Given this list of marker genes Slc23a1, Zfp983, Cntnap2, 6330403K07Rik, Pkhd1l1, Grap2, Isg15, Prnp, Pak6, Sfrp1, C1qtnf4, Map2k6, Dusp8, Trgv4, Fhl1, Gadd45g, Jun, Gadd45a, Lrrc39, Jund, Itgb7, Asb1, here is a description of the gene set: Genes up-regulated in fetal liver (days E13.5 and E15.5) samples from embryo-specific Cre-lox knockout of MAPK14. Mouse Gene Set: HUI_MAPK14_TARGETS_UP from publication Hui L, Bakiri L, Mairhorfer A, Schweifer N, Haslinger C, Kenner L, Komnenovic V, Scheuch H, Beug H, Wagner EF (PMID 17468757) The mitogen-activated protein kinase (MAPK) p38alpha controls inflammatory responses and cell proliferation. Using mice carrying conditional Mapk14 (also known as p38alpha) alleles, we investigated its function in postnatal development and tumorigenesis. When we specifically deleted Mapk14 in the mouse embryo, fetuses developed to term but died shortly after birth, probably owing to lung dysfunction. Fetal hematopoietic cells and embryonic fibroblasts deficient in p38alpha showed increased proliferation resulting from sustained activation of the c-Jun N-terminal kinase (JNK)-c-Jun pathway. Notably, in chemical-induced liver cancer development, mice with liver-specific deletion of Mapk14 showed enhanced hepatocyte proliferation and tumor development that correlated with upregulation of the JNK-c-Jun pathway. Furthermore, inactivation of JNK or c-Jun suppressed the increased proliferation of Mapk14-deficient hepatocytes and tumor cells. These results demonstrate a new mechanism whereby p38alpha negatively regulates cell proliferation by antagonizing the JNK-c-Jun pathway in multiple cell types and in liver cancer development. studied in species Mus musculus